Given this list of marker genes FRY, GP9, SPTLC2, RASAL2, CD2, DGKH (NCBI Gene Id 8524), IRF4, NELFE, AHNAK, FBXO36, GPR45, PLOD1, SYPL1, LCN12, NRN1L, KLF13, MT4, RORA, ITM2B, CES2, CASR, TEX14, KIF26B, PTGS1, RNASEK, STON2, ANKRD33, SLC37A2, SAP18, TMPRSS5, BICD1, EPHA4, VPS8, LINC-PINT, FCGR2B, AKAP4, SRPRB, USP3, DCT, NMNAT3, LRAT (lecithin retinol acyltransferase), ART3, KLRG1, RAP2A, LGALS3, IL1RL1, TAF13, DOCK5, NOTO, CCDC25, NLRP6, CAPN2, ARSB, PAFAH2, CTU2, TNIP3, LRRC56, AICDA, KCTD14, KCNH7, TPM3, TGFBR3, EFNB1, PTMS, STX4, KCNJ8 (NCBI Gene Id 3764), CALM2, OGFOD2, SHISA6, CBR1, EMP3, CX3CR1, ZMIZ1 (NCBI Gene Id 57178), SLC15A3, TCN2, LRRC8A, SLC6A18, CD33, MED20, SPATA16, FSCN2, FZD1, ABHD12, OVOL1, SUSD1, CLEC18A, ADAP2, LGALS1, C18orf32, CACNA1I, PTCD2, FBXO40, CNN3, IL25, LAG3, ACSL4, CSF1R, PIDD1 (p53-induced death domain protein 1), STARD10, PTK7, MYH7B, MIR208A (NCBI Gene Id 406990), RNF148, S100A11, AGTR1, TMEM163, CIR1, TLCD3B, F13A1 (coagulation factor XIII A chain), TPMT, COBLL1, CHIT1, EDN2, VHL, PLA2G10, IL2RA, HOXB6, CYTH4, MYLK4, S1PR5, PEX6, MEOX2, EIF4E, LPCAT1, GATD3, CSPG4BP, ITSN1, SLC30A2, HAVCR2 (hepatitis A virus cellular receptor 2), MYL6B, ARHGAP24, ANXA1, RRBP1, DAPP1, PCDH12, CCL4, EGF, MYOM2, FOXN4, TSPAN2, OSBPL3, AFAP1, TRPM3, LAMC1, SRCIN1, H2BL1P, NAGPA, REEP5, NBAS (NCBI Gene Id 51594), RAB8B, TEKTL1, CCPG1, PAX1, NADSYN1, CNIH4, RDH10, GSAP, ATP2A3, here is a description of the gene set: Genes down-regulated in spleen from mice injected with LPS: DUSP1 knockout versus wildtype. Activation of the Mitogen activated protein kinase (MAPK) cascade following Toll-like receptor (TLR) stimulation enables innate immune cells to rapidly activate cytokine gene expression. A balanced response to signals of infectious danger requires that cellular activation is transient. Here, we identify the MAPK phosphatase Dual specificity phosphatase-1 (DUSP1) as an essential endogenous regulator of the inflammatory response to LPS. DUSP1-deficient (DUSP1-/-) bone marrow derived macrophages showed selectively prolonged activation of p38 MAPK and increased cytokine production. Intraperitoneal challenge of DUSP1-/- mice with LPS caused increased lethality and overshooting production of IL-6 and TNF-alpha. Transcriptional profiling revealed that DUSP1 controls a significant fraction of LPS-induced genes, that includes IL-6 and IL-10 as well as the chemokines CCL3, CCL4 and CXCL2. In contrast, the expression of the important mediators of endotoxin lethality, IFN-gamma and IL-12, was not significantly altered by the absence of DUSP1. These data together demonstrate a specific regulatory role of DUSP1 in controlling a subset of LPS-induced genes that determines the outcome of endotoxin shock. studied in species Homo sapiens from publication Hammer M, Mages J, Dietrich H, Servatius A, Howells N, Cato AC, Lang R (PMID 16380512) Human Gene Set: GSE3565_DUSP1_VS_WT_SPLENOCYTES_POST_LPS_INJECTION_DN